Given this list of marker genes Cyp27b1, Snw1, Vdr (vitamin D (1,25-dihydroxyvitamin D3) receptor), Rxra, Mn1, Rxrb, here is a description of the gene set: Any process that activates or increases the frequency, rate or extent of vitamin D receptor signaling pathway activity. studied in species Mus musculus Mouse Gene Set: GOBP_POSITIVE_REGULATION_OF_VITAMIN_D_RECEPTOR_SIGNALING_PATHWAY